The following is a description of a gene set: The chemical reactions and pathways involving the ammonium ion. Mouse Gene Set: GOBP_AMMONIUM_ION_METABOLIC_PROCESS studied in species Mus musculus, and this is the list of marker genes: Btbd9, Chka, Mdga1, Fev (FEV transcription factor, ETS family member), Hnmt, Hdc (histidine decarboxylase), Cyp2d22, Aldh2, Bche, Tph1, Atp7a, Grin2a, Prg3, Pde1b, Gch1, Maoa, Dmgdh, Htr1a, Tph2, Rnf180, Ddc, Aldh7a1, Ache, Spr, Atp2b2, Enpp6 (ectonucleotide pyrophosphatase/phosphodiesterase 6), Chdh, Trh